The following is a description of a gene set: Human Gene Set: WP_DNA_DAMAGE_RESPONSE DNA damage response species: Homo sapiens, and this is the list of marker genes: CDK6, BID, CDK5, GADD45A, CASP3, FAS, RAD50, RB1, RAD51, CASP8, PIDD1, CDKN1A, AKT1, MRE11, CDC25C, RAD1, ATRIP, MDM2, CCNB2, TP53AIP1, CDC25A, CCND2, CHEK1 (NCBI Gene Id 1111), RRM2B (NCBI Gene Id 50484), PMAIP1, SFN, APAF1, GADD45B, RAD52, CCNB3, HUS1B, SMC1A (structural maintenance of chromosomes 1A), CCNB1, ATR, TP53, ATM, TLK1, BBC3, ABL1 (NCBI Gene Id 25), PRKDC, E2F1, RFC1, CCND3, CDK1, CDK4, PML, BRCA1, CREB1, CASP9, BAX, RAD17, RAD9A, DDB2, GADD45G, MYC, SESN1, CCND1, TNFRSF10B, CDKN1B, CHEK2, FANCD2, CDK2, NBN, RPA2, TLK2, CYCS, CCNE2, CCNE1, H2AX